Given this list of marker genes Srl, Manf, Calr, Hsp90b1, Casq1, Casq2, Calu, here is a description of the gene set: studied in species Mus musculus Mouse Gene Set: GOCC_SARCOPLASMIC_RETICULUM_LUMEN The volume enclosed by the membranes of the sarcoplasmic reticulum.